Given this list of marker genes ADCY9, CALM1, CAMKK2, ADCY3, ADCY5, CAMK2B, ADCY1, PRKAR1A, PDE1A, PRKACB, PRKACA, ADCY8, ADCY6, PRKCD, KPNA2 (karyopherin subunit alpha 2), PRKX, PRKAR1B, NBEA, CAMK2G, PRKACG, PRKCA, ADCY7, PLA2G4A, PDE1B, MAPK1, ADCY4, PRKCG, CAMKK1, CAMK2D, CAMK2A, GRK2, CREB1, PDE1C, PRKAR2A, CAMK4, ADCY2, PRKAR2B, here is a description of the gene set: Calcium, as the ion Ca2+, is essential in many biological processes. The majority of Ca2+ in many organisms is bound to phosphates which form skeletal structures and also buffer Ca2+ levels in extracellular fluids (typically 1 millimolar). Intracellular free Ca2+, by contrast, is 10,000 times lower than the outside of the cell (typically 10 micromolar). This concentration gradient is used to import Ca2+ into cells where it acts as a second messenger. part of: PLC beta mediated events Reactome Pathway: Ca-dependent events species: Homo sapiens